The following is a description of a gene set: species: Mus musculus Mouse Gene Set: GOBP_NEGATIVE_REGULATION_OF_ASTROCYTE_DIFFERENTIATION Any process that stops, prevents, or reduces the frequency, rate or extent of astrocyte differentiation., and this is the list of marker genes: Hmga2, F2, Nr1d1, Id4, Mycn, Trem2, Fgfr3, Gpr37l1, Nog, Mecp2, Dll3, Ldlr, Mbd1, Nf1, Kdm4a, Ntrk3, Hes5, Dab1, Nr2e1, Atf5